The following is a description of a gene set: Human Gene Set: GOBP_VESICLE_MEDIATED_TRANSPORT_TO_THE_PLASMA_MEMBRANE species: Homo sapiens The directed movement of substances to the plasma membrane in transport vesicles that fuse with the plasma membrane by exocytosis., and this is the list of marker genes: EHD3, DENND1B, EPS15, VPS50, RAB11FIP4, RACK1, LYPLAL1, RAB8B, PREPL, NSG1, EXOC6B (exocyst complex component 6B), VPS35L, MTMR4, RAB26, STX16, RAB34, NDRG4, EHD2, ARL4C, RAB11B, STXBP5L, VPS53, CLSTN1 (NCBI Gene Id 22883), GOLGA4, CSK, EXOC5, BBS2, COMMD1, PLA2G3, OSBPL5, GOPC, VAMP4, WASH3P, GGA1, SLC1A1, CCDC22, CLN3, CMTM6, ANKRD27, ARL3, BLTP1, CPLX1, CCDC93, PKDCC, GCC2, AMN, GOLPH3, AKAP5, GGA3, SNX27, ARFRP1, ANKRD50, VPS26A, EXOC1, PHAF1, TRARG1, RABEP1, SNX7, GGA2, ARHGAP44, STX6, ATP2C1, KRT18, STX3, VPS26C, C2CD6, VAMP2, SORL1, LMTK2, RSC1A1, BLZF1, ATP9A, RAB14, RAB8A, RAB35, SCARB2, LLGL1, VAMP5, MICALL1, ATP6AP1, WASHC1, VPS35, PLA2G4E, EHD1, SNX31, ENTR1, WASHC2C, STX12, GRIP1, SNF8, EXOC4, SEC16A, ARHGAP8, VPS29, EXOC6, RAB12, VPS39, WASH6P, RAB7A, EHD4, ANXA13, RAB11FIP3, STXBP5, GRIPAP1 (NCBI Gene Id 84538), EXOC8, RAB10, DENND1A, ACSL3, ARFGEF2, VPS52, SCRIB, SNX4, STEAP2, EXOC2, RAB17, INPP5F, BVES (NCBI Gene Id 11149), EPG5, GOLGA7, VTI1A, ARF6 (ADP ribosylation factor 6), ARHGAP1, LRRC7, PTPN23, KIF13A, VPS13B, MICALL2, WIPF3, LLGL2, ZDHHC2, RAB11A, CNST, SNX17, ANK3, EIPR1, VPS51, OPTN, GOLPH3L, SNX3, VAMP3, BBS1, HGS, DEF6, SNX12, NSF, RAB3IP, ACAP2, RAB31, SPTBN1, GRIP2, RAB13, LYPLA1, SYS1, DENND1C, SNX30, ACTN2, MACF1, SACM1L